The following is a description of a gene set: species: Homo sapiens Binding to a U4 small nuclear RNA (U4 snRNA). Human Gene Set: GOMF_U4_SNRNA_BINDING, and this is the list of marker genes: RNU6-9, SNU13, PRPF4, GEMIN5, PRPF31, SART3, RNU6-7, DDX39B, RNU6-1